The following is a description of a gene set: Human Gene Set: GSE28726_ACT_CD4_TCELL_VS_ACT_NKTCELL_UP Microarray analysis was performed to determine the transcriptional profiles of NKT, CD1d-aGC+ Va24-, and CD4 T cells. from publication Constantinides MG, Picard D, Savage AK, Bendelac A (PMID 21632718) studied in species Homo sapiens Genes up-regulated in activated T cells: CD4 versus NKT., and this is the list of marker genes: NT5E, ADAM19, PEX3 (peroxisomal biogenesis factor 3), IL1B, RCN1, MACF1, PSMD1, MRPS27, TCOF1, SNRPC, NIT1, NME1, FABP5, BRD8, ELMO1, TXN, PDIA3, CCT4, ADARB1, PSMD7, ZNF200 (NCBI Gene Id 7752), SPAG9 (sperm associated antigen 9), LAMP3, PGK1, MTA1, PPT1, NKRF (NFKB repressing factor), FASLG, SNAPC1, RAB27A, PDCD2, CTTN, HIVEP2, IDI1, GTF2H5, NDEL1 (nudE neurodevelopment protein 1 like 1), NUP88, ATP6V1A, SRI, SPRY1, MTREX, MKLN1, DDB1 (damage specific DNA binding protein 1), GTPBP6, NUP160, NPC1, FUS, SDHD, HNRNPDL, ZBTB24, PALLD, GFUS, BET1, URB2, UTP25 (NCBI Gene Id 80064), SP3, R3HDM1, RGS10, HNRNPA3, MARS1, IL18RAP, ISG20L2 (NCBI Gene Id 81875), CEP170, GAD1, VDAC1, AGO2, HDDC2, PPID, CFDP1, VIM, ENO1, MMACHC, MAPRE2, AP4S1, HCCS, CCDC86, GTF2E2, NFATC1, NHP2, C1orf216, HNRNPF, S100A11, DIMT1, PREP, BHLHE40, CDK4, IPO5 (importin 5), GNG5, DHCR24, RFC3, CDK2AP1, PPP2CA, SLC29A1, DDX18, ATXN1, TXNDC9, LDHA, CAPN15, GNAI1, GEMIN4, TOR1B, EIF3I, DBI, GZMB, TPI1, METTL1 (methyltransferase 1, tRNA methylguanosine), RRP7A, IQCB1, UBE2D1, CD28, DUSP5, ADO, RRAS2, ABCB6, MYDGF, APOBEC3B, LRRC8B, CAND1, TNF, SUB1, RPA2, IL1R1, OSGEP, LPCAT1, SRPK1, ZNF195, TXNL4A, PMPCA, DDX42, PPP1CC, ACSL1, LYST, HMGN4, VDAC3, GGCT, SNAPC4, JPT2, HYOU1, SF3B3, ZNHIT3, MRPS12, NSMAF, CFLAR, CUL1, POP4, NPM1, HSP90AB1, IL2RA, RUVBL2, SRM, TNFRSF1B, PSME3, HOMER1, LRRN3, POLR2G, FH, ATXN10, TXLNA, CYB5B, UBE2G2, NFYA (NCBI Gene Id 56008), NFE2L3, AATF, NFKB1, AMD1, GAPDH, MAPKAPK3, EGR3, EIF3J, TRA2B, COPS8, CCL4, TIMM17A, CANX (NCBI Gene Id 821), TMEM243, HINFP, NUTF2, INPP5F, STK4, LYSET (NCBI Gene Id 26175), RFC4, NDUFS6, RPN2, NADK, PEA15, MBD3, TUBA1B, TRIAP1, ACSL3, HPS5, WNK1, HPRT1, SCAMP3, PGAP1, PSMB6 (NCBI Gene Id 95505), DLAT, NUFIP1, RPA3, PKM, SUCLA2